Given this list of marker genes HSPA8 (heat shock protein family A (Hsp70) member 8), IFRD1, HNRNPUL1, TMED9, GPAA1, MYDGF, PSMB2, XPO7, RAD23A, YWHAQ, BRD8, ACTR3, FAM120A, PSMB7, EIF4H, GPN1, AFG3L2, KHDRBS1, CS, VDAC2, GANAB, DYNLL1, PSMB1, NARS1, CAP1, BZW1, HNRNPU, SLC25A3, WDR1, XRCC5, SND1, IMPDH1 (NCBI Gene Id 6105), TRAPPC3, FAM168B, HADHB, HDAC1, CTDNEP1, TARDBP, CTBP1, MCFD2, CYB5R3, ATP5MC3, SSB, AP3D1, VDAC3, RUVBL2, PSMD1, CSNK2B, PDIA6, ATXN10, YWHAB, DCTN2, DNAJC8, ZNF146, SUMO2, UQCRH, COASY, NONO, FKBP1A, SNRPA, GAK, CUL1, COPS5, TCEA1, CAPZA1, NDUFS4, NDUFC1, RHEB, SDHA, CCT7, RTCB, HAX1, FBXW11, FNTA, COX5B, COX7C, PTBP1, ANAPC5, AP3S1, POLR2I, IMMT, ILF2 (interleukin enhancer binding factor 2), GNB1, TXNL4A, SSBP1, NRDC, CANX, MAP2K2, STK24, NCOR2, G3BP2, LSM2, NDUFB3, STARD7, PPP2CA, UBE2L3, IDH3B, MDH1, CAPZB, PIN1, ATP5PF, POLR2L, KXD1, PRKAR1A, XRCC6, RBMS1, HNRNPA2B1, AP2M1, SNRNP200, ARPC5, MGRN1, EIF2S2, BAG6, RTN4, AHCYL1, PSMA4, SREBF2, CARS1, PDHB, ATP5PO, TIAL1 (NCBI Gene Id 8430), TAX1BP1, NDUFS2, SRSF9, SEPTIN7, ACLY, PGAM1, KARS1 (NCBI Gene Id 3735), XPO1, PGK1, here is a description of the gene set: Neighborhood of AP3D1 studied in species Homo sapiens Human Gene Set: MORF_AP3D1 Neighborhood of AP3D1 adaptor-related protein complex 3, delta 1 subunit in the MORF expression compendium